The following is a description of a gene set: Human Gene Set: GOBP_PLACENTA_BLOOD_VESSEL_DEVELOPMENT studied in species Homo sapiens The process whose specific outcome is the progression of a blood vessel of the placenta over time, from its formation to the mature structure., and this is the list of marker genes: AKT1, SOCS3, NR2F2 (NCBI Gene Id 7026), MAPK1, PLCD3, PKD1, GGNBP2, HS6ST1, RBPJ, RBM15, OVOL2, PLG, LLGL2, ITGB8, HEY2 (NCBI Gene Id 30830), HEY1, SPINT1, MAP2K1, MIR16-1, VASH1, PKD2, NOTCH2, VASH2 (vasohibin 2), APELA, HES1, NSDHL, JUNB, TMED2, WDR83, CCN1, FBXW8, WNT2, FOSL1, FZD5